The following is a description of a gene set: The movement of substances between cells via gap junctions. A gap junction is a fine cytoplasmic channel, found in animal cells, that connects the cytoplasm of one cell to that of an adjacent cell, allowing ions and other molecules to pass freely between the two cells. studied in species Mus musculus Mouse Gene Set: GOBP_GAP_JUNCTION_MEDIATED_INTERCELLULAR_TRANSPORT, and this is the list of marker genes: Gja8, Map3k8, Mip, Gjb2, Gjb4, Gja3, Gjb6